The following is a description of a gene set: species: Homo sapiens A heterochromatin formation-based gene silencing process mediated by a regulatory non-coding RNA molecule that occur before the beginning of trancription. Human Gene Set: GOBP_REGULATORY_NCRNA_MEDIATED_HETEROCHROMATIN_FORMATION, and this is the list of marker genes: TDRD5, ARB2BP, XIST, TDRD1, EZH2, MAEL, DNMT3L, PIWIL2 (NCBI Gene Id 55124), TDRD9, ZNFX1, SPOCD1, DNMT3A, PIWIL4, PARTICL, HNRNPK, FKBP6, SPIN1 (NCBI Gene Id 95616), SPEN, NRDE2, MOV10L1, ARB2A, HNRNPU, PIWIL1, DDX4, TDRD12, PTENP1-AS, C19orf84